The following is a description of a gene set: Human Gene Set: HP_ABNORMAL_CEREBRAL_ARTERY_MORPHOLOGY studied in species Homo sapiens Abnormal cerebral artery morphology Any structural anomaly of a cerebral artery. The cerebral arteries comprise three main pairs of arteries and their branches, which supply the cerebrum of the brain. These are the anterior cerebral artery, the middle cerebral artery, and the posterior cerebral artery., and this is the list of marker genes: IFIH1, MFAP5, RNF213, TGFBR1, RNASEH2B, ABCG5, TGFBR2, ACTA2, COL1A1, MYLK, APOB, ABCG8, IFT140, ALDH18A1, THSD1, MAT2A (NCBI Gene Id 4144), ADAR, NDE1, NFIA, RNU4-2, MYH11, FARSB, TONSL, PRKAR1A, ANO1, PCNT, SAMHD1, APP, COL5A2, NF1, GANAB (NCBI Gene Id 5312), SLC20A2, SMAD3, HTRA1, PDE11A, TREX1, RNASEH2A, SMAD4, HEY2, ELN, LOX, APOA1, PKD1, DNAJB11, RNASEH2C, COL4A1, ALG5, TGFB3, THSD4, FOXE3, PKD2, GGCX, TGFBR3, TGFB2, GAA, LDLRAP1, PLOD3, GUCY1A1, ANGPTL6, PRKCSH, STAT1, BRCC3, PRKG1, PDGFRB, LSM11, SEC63 (SEC63 homolog, protein translocation regulator, NCBI Gene Id 55399), FBN1, ENG, SMAD2 (NCBI Gene Id 654050), COL3A1, RNU7-1, BICC1 (NCBI Gene Id 80114), ALG9, SPTBN1, SMARCAL1, LDLR (NCBI Gene Id 3949), HES7, BGN, PCSK9, COL5A1, PDGFB (NCBI Gene Id 5155), IPO8, LRP5